Given this list of marker genes Heg1, Ccbe1, Efnb2, Notch1, Pitx2, Ccm2, Prox1, Ephb4, Notch4 (NCBI Gene Id 224712), Eng, Tbx20, Chrd, Vegfa, here is a description of the gene set: studied in species Mus musculus The process in which the anatomical structures of venous blood vessels are generated and organized. Veins are blood vessels that transport blood from the body and its organs to the heart. Mouse Gene Set: GOBP_VENOUS_BLOOD_VESSEL_MORPHOGENESIS